The following is a description of a gene set: FGFR1 ligand binding and activation species: Homo sapiens Human Gene Set: REACTOME_FGFR1_LIGAND_BINDING_AND_ACTIVATION, and this is the list of marker genes: GIPC1, FGF23, FGF5, FGF8 (fibroblast growth factor 8), FGF3, FGF2, KL, FGF20, FGFR1, FGF4, FGF9, TGFBR3, FGF22, FGF17, ANOS1, FGF6, FGF10, FGF1